The following is a description of a gene set: Human Gene Set: GSE7218_UNSTIM_VS_ANTIGEN_STIM_THROUGH_IGM_BCELL_DN Genes down-regulated in B lymphocytes expressing IgM - BCR: untreated versus anti-HEL. studied in species Homo sapiens IgG cytoplasmic tail interferes with the induction of antigen-response genes from publication Horikawa K, Martin SW, Pogue SL, Silver K, Peng K, Takatsu K, Goodnow CC (PMID 17420266), and this is the list of marker genes: SLC25A15, GRIA1, AKAP10, GAP43, TNFRSF14, VCAN, CCNJ, ESCO1, DNAAF4, F2RL1, PANK3, PRPH, CTU2, LIN28B, CIITA (NCBI Gene Id 4261), CRYBA4, LUC7L2, MMAA, VEPH1, LIPT1, ATPSCKMT, PGAP3, ZC3H7A, PLAGL2, MIR103A2, MXD3, CENPJ, RFX8, FBXO9, TPD52L1, RHEBL1, TERB1, PAPSS1, ZFP82, PRPF40B, TSPAN8, IL18R1, RAB18, SPINK2, RNASE13, HCRT, PTPN6, APBA1, GTF2H2, RIF1, NSG1, EPHX2, YTHDC2, PRKCI, ATP10D, LRRTM1, THRAP3, HOXB6, IFNG, CASS4, GPR19, PROP1, RIPK2, MIR27A, NOL12, PRSS3, ELAVL4 (NCBI Gene Id 1996), FLACC1, TACR2, LCE6A, TSPYL4, CD79B (CD79b molecule), YTHDC1, FUT2, TRAF3IP1, SLC30A2, TFB2M (transcription factor B2, mitochondrial), SMC6, PLCXD1, PRAMENP, FKTN, NRL, TIMD4, NAT2 (NCBI Gene Id 10), MAP3K13, JSRP1, KCNRG, RAP2C, POTEG, OXT, ZZZ3, SFRP1, MYL10, ADAMTS3, DEK, GPR82, HIC1, CCDC88A (NCBI Gene Id 731560), CUL4A, CLDN23, TRIT1, MIR23B, TMEM82, SYNPR, GNRH1, TMPRSS4, PRP4K, NPAS4, PAF1, NOL4, ZDHHC17, ANGPTL1, GFI1, SCN4B, ZFP69, CHRM3, PLN, CCDC14, HNRNPR, ARFRP1, LY6K, CEP44, HMGCS1, PELI1, MOSMO (modulator of smoothened)